The following is a description of a gene set: Human Gene Set: GOBP_DETECTION_OF_LIPOPOLYSACCHARIDE The series of events in which a lipopolysaccharide stimulus is received by a cell and converted into a molecular signal. Lipopolysaccharide is a major component of the cell wall of gram-negative bacteria. studied in species Homo sapiens, and this is the list of marker genes: TREM2, TLR4, NR4A1, LY96, SCARB1